The following is a description of a gene set: Human Gene Set: HP_CALF_MUSCLE_PSEUDOHYPERTROPHY Enlargement of the muscles of the calf due to their replacement by connective tissue or fat. studied in species Homo sapiens Calf muscle pseudohypertrophy, and this is the list of marker genes: POMT2, PPARG, CAV3, CRPPA, POMT1, SGCG, GMPPB, MYH7, SGCA, DMD, FKRP, SGCB, POMK, SNUPN, TRIM32, DAG1, NEB, ANO5, LMNA, POMGNT1